Given this list of marker genes ACSF2, TNFRSF21 (NCBI Gene Id 51323), TOP2B, GIMAP6, TNS3 (tensin 3), PKP4, TUT4, ATRX, PAG1, MOB3A, SEPTIN6, PRP4K, ARID1A, PRKD2, ZFC3H1, LDLRAD3, ZNF207, RRM2B, CHD9, SOX4, SMCHD1 (NCBI Gene Id 2490), MAP7, ARID4A, INSIG1, VIRMA, NEDD9, COBLL1, CBX3, CCNH, SCAI, LTB, SLC4A7, PARP8, SMC5, CDKL3, XPO1, SLC46A3, RNF130, PDE7A, FCRL1 (NCBI Gene Id 115350), ALCAM, FFAR2, CEP97, TMEM108, ARID1B, ETS1, PXK, KLHL24, LDLR, ARPC5L, HSD11B1, BMP2K, STK10, CEP43, RALGPS2, SEMA3D, NDUFAF5, CAMKMT, ZPBP2, ELL3, ZNF292, LRATD2, DDIAS, POLG2, GCNT1, ACAP1, TRIM7, RAB32, NOTCH2, ATAD2B, GLUL, LPIN2, F13A1, ZFP36L1, SLAIN1, ATOSA, TMEM131L, ID3, MYL4, FKBP3, PEX11G, TTK, ARRDC3, LYNX1, HEXB, CD40, FOXO3, MSL1, RFX5, KMO, CD200, LAIR1 (NCBI Gene Id 3903), BCOR, RELCH, DSC3, SKA2, TRAF5, BACH1, CADM1, HNRNPH3, PTTG1, NLRC3, ATP8A1, CD93, GGNBP2, SMC6, LIMD2, SLC25A37, ZNF229, EDARADD (EDAR associated via death domain), UBLCP1, MTCP1, DOCK11, MTMR4, PI4K2B, STK26, INPP5F, RSRP1, TSGA13, TBC1D14, PAN3, MXD4, RFC1, CSNK1G3, CALHM6, MAP2K1, IGLL1, ANAPC4, UPF3B (NCBI Gene Id 65109), HLA-B, GSN, CR2, GANC, SORL1, DENND2D, C2orf88, ZNF490, SFXN2, BCL10, SLC14A1, DYRK2, TM6SF1, RGS10, BPGM, LMO2, STAP1, DDX25, FLI1, XCL1, TERB1, CD84, SRPK3, VPREB3, LCOR, TNPO1, MBD4, DUSP6, PGAP1, GPR174, RASA2, CTSO, TNFRSF13C (NCBI Gene Id 115650), C5orf34, CD52, HLA-DOA, PELI1, FCMR, FH, RASGRP3 (RAS guanyl releasing protein 3), BRWD1, NRXN1, CNR2, IL16, PAIP2, TMED8, SDCCAG8, CREBL2, RREB1, CHCHD10, TMEM209, PRKACB, SLC12A6, IGLC7, CCDC107, FYCO1, CEP68, ING1, ACSS1, PLCXD2, RRAS2, NCK2, HLA-DOB, ICOSLG, MEX3B, IDH2, ZNF608, GM2A, EPB41L2, H2BC13, CARD6, here is a description of the gene set: from publication Yang XD, Ai W, Asfaha S, Bhagat G, Friedman RA, Jin G, Park H, Shykind B, Diacovo TG, Falus A, Wang TC (PMID 21170045) Genes up-regulated in myeloid-derived suppressor cells from bone marrow: wildtype versus HDC knockout. species: Homo sapiens Human Gene Set: GSE23502_WT_VS_HDC_KO_MYELOID_DERIVED_SUPPRESSOR_CELL_BM_UP Differentially expressed genes of CD11b+Gr-1+ immature myeloid cells (IMCs) in the bone marrow and colonic tumor setting of histidine decarboxylase (HDC)-KO mice were examined by microarray (Affymetrix Mouse 430.2 array). Myeloid differentiation-related candidate genes were sought to be isolated and functionally studied.